The following is a description of a gene set: species: Mus musculus Mouse Gene Set: GOBP_POSITIVE_REGULATION_OF_STEROID_HORMONE_SECRETION Any process that activates or increases the frequency, rate or extent of steroid hormone secretion., and this is the list of marker genes: Mfn2, Retn, Dab2, Galr1, Nkx3-1, Cyp2j5, Spp1, Ecrg4, C1qtnf1, Bmp6, Cyp19a1, Runx1, Ghrl, Gal (galanin and GMAP prepropeptide), Tac1, Crh